Given this list of marker genes UL54, NUP42, H2AC7, UL144, H2BC1, NEC2, TRS1, H2BC17, POM121C, UL29, UL102, NUP160, VPS4A, H2BC11, gH, UL112/UL113, TRM3, CHMP3, gB, NUP50, H2AC1, NUP210, gM, UL24, CVC1, UL146, US22, H2AC11, RL9A, UL48, UL31, UL36, UL117, UL26, UL23, UL88, NUP98, UL147A, UL35, CEBPD, NUP62, NUP133, H2BC18, NUP205, UL131A, CHMP4C, UL130, UL122, CHMP6, UL99, CVC2, CHMP2B, MVB12B, UL52, NUP107, CHMP7, UL70, H2BC3, UL69, NUP35, UL47, UL18, Hh5 strain Merlin complete genome, UL87, UL91, UL148, RANBP2, UL120, UL104, gN, H2AC18, IRS1, TRM2, H2AC20, RL8A, SNF8, US32, H2BC14, H2AC25, UL147, UL82, UL96, NUP54, UL9, UL84, SEH1L, NDC1, UL25, H2BC9, VPS37C, H3C1, VPS37A, SEC13, UL80, POM121, UL92, H2AC12 (NCBI Gene Id 85235), gL, RAE1, NUP58, UL79, VPS25, H2AC21, H2BC15, TRM1, TRX2, AAAS, NUP88, VPS37D (VPS37D subunit of ESCRT-I), CHMP4A, UL76, NUP85, NUP188, SCP, UL121, NUP37, UL44, UL74, UL14, UL15A, NUP93, UL83, H2AC4, UL111A, H2BC13 (NCBI Gene Id 8340, H2B clustered histone 13), H3C15, UL2, TPR, MVB12A, CHMP1A, H2AC6, UL22A, UBAP1, UL38, H2BC12, VPS37B, H2AC14, VPS28, H2BC21, UL95, H2BC4, NUP155 (nucleoporin 155, NCBI Gene Id 9631), H2BC5, UL71, US23, DBP, H2BC26, NEC1, UL41A, CHMP2A (NCBI Gene Id 27243), UL132, NUP153, TSG101, UL7, H4C1, UL43, CHMP4B, UL97, TRX1, NUP214, RL11, VPS36, MCP, RIR1, UL103, UL94, HELI, RNA4.9, UL32, HNRNPK, NUP43, here is a description of the gene set: studied in species Homo sapiens Reactome Pathway: HCMV Late Events Once Human Cytomegalovirus (HCMV) Immediate Early (IE) and Delayed Early (DE) gene products begin to appear the processes driving DNA replication, Late (L) gene expression, and virion assembly begin. part of: HCMV Infection